Given this list of marker genes DTX1, ZNF227, MUS81, ATP2A2, KIAA1958, PPIF, RMDN2, PFKP, SSR1, AVIL, PAK6, ARHGEF9, APTX, MYO10, IL12RB2, UBE2I, PAFAH1B2, RNASEK, MGAT2, PAQR4, MAFG, PLK3, GTF2A1 (general transcription factor IIA subunit 1), SQLE, PIP5K1A, ANO8, AFF2, RAB11FIP4, MLLT11, HAX1, ADORA2B, AGFG2, CD164, AGGF1, LPCAT3, TRMT61A, SYVN1, ACTC1, ARPC5L, SHC4, ELAC2, TM7SF2, COPB1, CEP43, ARL8B, ALPK2, ABRAXAS1, BOD1, ARAF, FCER1G, WDR77, TFEB, BAIAP3 (NCBI Gene Id 8938), GRPEL2, ENTPD7, PRORP, PTK2B, NDEL1, PWP1, RAB20, NEK6, PSMC3, SEPTIN11, CEBPZ, UBXN2A, PREPL, HESX1, B4GALNT4, ASNS, ITPK1, LGALSL, MPZL1, ELOVL1, FADS3, METRNL, NMT1, UBTF, BTBD10, HSPA1B, RAP2A, SLC10A7, IVD, DLAT, SRP54, SLC25A6, CYP51A1, TSR1, CCDC86, SLC16A6, ARPC1B, WDR6, INTS14, PDE8A, FADS2, PPP2R2C, GARS1, FAM177A1, DHRS11, YARS1, UBQLN1, PSD4, FKBP5, ARL15, MRPS34, YTHDF1, B4GALNT2, DDX3X, STX18, KLHL30, HSPA9, ATAD3A, DNAJA2, MRPL10 (NCBI Gene Id 65004), ZFAND2A (zinc finger AN1-type containing 2A), TOMM34, USP5, TNFRSF21, USO1, NEMF, EPHX4, PLXND1, PIGQ, PPP2R3C, ABHD11, INTS2, VPS8, IDE, CBX4, PEX19, DDIT4 (DNA damage inducible transcript 4), CENPJ, DCUN1D4 (NCBI Gene Id 23142), PUS10, BCL2L1, AKIRIN1, PSMC5, NDUFS1, ABI3, OGDH (NCBI Gene Id 4967), SLC16A10, CDC42EP3, HMGCS1 (3-hydroxy-3-methylglutaryl-CoA synthase 1), BAG2, RPGRIP1, C5orf22, SHMT2, ALG1, TNFRSF12A, COPG1, CRYBG2 (NCBI Gene Id 647881), STAT3, TMEM19, ATP6V1B1, MIR22HG, UROS, ARF1, OSBPL3, FDPS, C1orf122, RBMX, VCP, RHOT1, CERS2, ABCE1, ACIN1, ADGRG3, HSPA4, WNT10B, MESD, DDA1, PUM3, TP53INP2, WDR12, MAP10, KPNA1, MAPK9, TRAPPC14, GPATCH4, COMMD10, VAT1L, GFER, TMED7, PGD, DOLK, UBE2F, CTU2, CD320, GLMN, SHOC2, EIF4A1, TFF1, GFI1, ERGIC1, ZNF768, XPOT, F2RL2, CHRNG (NCBI Gene Id 1146), HSD17B7 (hydroxysteroid 17-beta dehydrogenase 7), MVD, FLT3LG, here is a description of the gene set: Human Gene Set: GSE6092_UNSTIM_VS_IFNG_STIM_ENDOTHELIAL_CELL_UP from publication Dame TM, Orenzoff BL, Palmer LE, Furie MB (PMID 17202382) studied in species Homo sapiens Borrelia burgdorferi, the agent of Lyme disease, promotes pro-inflammatory changes in endothelium that lead to the recruitment of leukocytes. The host immune response to infection results in increased levels of IFN-gamma in the serum and lesions of Lyme disease patients that correlate with greater severity of disease. Therefore, the effect of IFN-gamma on the gene expression profile of primary human endothelial cells exposed to B. burgdorferi was determined. B. burgdorferi and IFN-gamma synergistically augmented the expression of genes, seven of which encode chemokines. Six of these (CCL7, CCL8, CX3CL1, CXCL9, CXCL10, and CXCL11) attract T lymphocytes, and one (CXCL2) is specific for neutrophils. Synergistic production of the attractants for T cells was confirmed at the protein level. IL-1beta, TNF-alpha, and LPS also cooperated with IFN-gamma to induce synergistic production of CXCL10 by endothelium, indicating that IFN-gamma potentiates inflammation in concert with a variety of mediators. An in vitro model of the blood vessel wall revealed that an increased number of human T lymphocytes traversed endothelium exposed to B. burgdorferi and IFN-gamma, as compared to unstimulated endothelial monolayers. In contrast, addition of IFN-gamma diminished the migration of neutrophils across B. burgdorferi-activated endothelium. IFN-gamma thus alters gene expression by endothelium exposed to B. burgdorferi in a manner that promotes recruitment of T cells and suppresses that of neutrophils. This modulation may facilitate the development of chronic inflammatory lesions in Lyme disease. Genes up-regulated in endothelial cells: untreated versus IFNG.